Given this list of marker genes DMTN, RAP1A, ARF6, EZR, TRAF6, DOK7, C2CD5, PAK1, ERBB2 (NCBI Gene Id 2064), STX8, MRAP, CPLX1, PICALM, BCL2L1, NETO2, AP2B1, GPC3, TREM2, MIEF1, CAMK2A, PPP2R5A, PRKCI, GRIPAP1, STAC3, DPP10, GDI1, CEMIP, VAMP8, FNTA, CSK, TCAF2, HPCA, FRRS1L, ATP2C1, SIRT6, TNF, SLC5A3, GPC5, PPFIA1, AGR2, NRXN1 (neurexin 1), AKT1, MESD, TNFAIP6, SLC51B, VIL1, ATP2B4, EGFR, PIK3R2, ADAM10, MRAP2, SLC1A1, CAMK2G, MIR223, LRP1 (LDL receptor related protein 1), PKDCC, ZMYND8, VPS4A, SQSTM1, CDH2, IFNG, RSC1A1, PGRMC1, INS, FARP1, ARHGEF16, IQSEC2, STAC, MMP14, CACNA2D2, CLTC, CD81, GPER1, EPHA3, COMMD1, EPB41L3, KIF5B, NUMB, LRRC15, CRK, TMEM108, FYN, RER1, GSN, LYPD1, LYPLA1, LGALS3, RHOG, KCNE1, ITGB1BP1, CNST, WNK3, PRKCE (NCBI Gene Id 5581), RANGRF, VAMP4, SHISA7 (NCBI Gene Id 729956), SHISA6, DSG3, KCNB1, RAB11FIP2, CSRP3, SLC30A1, AKT2, PTPN9, EPHB2, RAB11A, VTI1B, MYO1C, NECAB2, ABI3, CLIP3, CDK5, PRKN, ZDHHC7, GPC1, ANK3, PIK3R1, PIK3CA (NCBI Gene Id 5290), MTCL1, STOM, AP2M1, GBP1, WNT3A (Wnt family member 3A), SFN, ITGA3, EPM2A, PLS1, TMBIM1, GPC6, RHOQ, LYPLAL1, GPC2, TMED2, KIF2C, STX4, DLG1, FZD9, MIEF2, STX7, WNK4, ZDHHC2 (NCBI Gene Id 51201), CIB1, TCAF1, SSH1, ZDHHC8, CAMK2B, ANXA13, HRAS, STX3, NHLRC1, RAMP3, EPHA2, CDK5R1, AR, EFCAB7 (EF-hand calcium binding domain 7), RAC1, SPTBN1, CNPY4, PDZK1, CRIPT, CACNG2, LDLRAP1, ACSL3, CLN3 (NCBI Gene Id 1201), PKP1, PPP1R9B, SORBS1, ZDHHC5, OLFM1, MAP2K1, GHSR, CRKL, TMEM59, ITGAM, ITGB1, OGT, NLGN2, DAB2, STAC2, INPP5K, USP17L2, ARHGAP44, PID1, NKD2, GPC4, WNK1, PDPK1, ITGB2, LRP4, SLC7A11, VPS26B, DAG1, LZTFL1, PRNP, ACTB, TGFB1, AKAP5, PRKCH, GABARAP, RACK1, CAMK2D, APPL1, CHP1, here is a description of the gene set: studied in species Homo sapiens Human Gene Set: GOBP_REGULATION_OF_PROTEIN_LOCALIZATION_TO_MEMBRANE Any process that modulates the frequency, rate or extent of protein localization to membrane.